Given this list of marker genes Pabpn1l, Zyx, Bmper, Btaf1, Myh10 (NCBI Gene Id 77579), Rbm26, Polr3h, Rnf181, Zfp644, Tcea1, Igsf9b, Ormdl2, Chst2, Serpini1, Dnmt3a, Dmd, Dnal1 (dynein, axonemal, light chain 1), Ptger4, Tlr3, Lepr, Kat2b, Ivns1abp, Npy5r, Eif3a, Ppp1r17, Alg13 (asparagine-linked glycosylation 13), Paqr8, Atxn1, Cask, Cxxc4, Tcf21, Rtbdn, Esyt2, Tollip, Pcmtd2, Pfkfb3, Foxo1, Slc6a14, Mbnl1, Tmeff1, Ppp1r21, Mef2c, Zfp626, Epb41l1, Fgg (fibrinogen gamma chain), Magi3, Pex12, Bmp5, Mcm2, Fgfr2, Slc10a2, Mroh9, Tbc1d10a, Pnisr, Olr1, Polr3e, Mpdz, Atp7a, Lyrm4, Uso1, Zfp652, Nts, Reep3, Cd9, AI593442, Micu3, Myo5c, Slc6a20b, Kalrn, Fbxo34, Naaa, Slitrk2, Slc35f1 (solute carrier family 35, member F1), Ncapd3, Gja8, Ago3, Polk, Srp54c, Ensa, Fgd4, Fcrl6, Zim1, Ptrhd1, Id4, Nanp, Abcb1a, Rap2c, Mc4r, Arhgap44, Adamts6, Ctdspl2, Fstl5, Adi1, Srp54b, Ubxn2b, Ash1l, Zfyve16, Itgb1bp1, Vwc2l, Enox2, Gtpbp2, Mgarp, Nedd1, Plcb1, Bicd1, Vkorc1l1, Zfp563, 9430038I01Rik, Zfp367, Guca1b, Tmprss11f, Hltf, Tectb, Cyp26b1, Poli, Serinc3, Ppp1r3a, here is a description of the gene set: Mouse Gene Set: MIR_701_3P studied in species Mus musculus from publication Chen Y, Wang X (PMID 31504780) Genes predicted to be targets of miRBase v22 microRNA mmu_miR_701_3p in miRDB v6.0 with MirTarget v4 prediction scores > 80 (high confidence targets).